The following is a description of a gene set: Abnormal lacrimal punctum morphology studied in species Homo sapiens An abnormality of the lacrimal punctum, an opening on the eyelid close to the medial canthus that drains tears from the conjunctival sac into the lacrimal duct in the same eyelid. Human Gene Set: HP_ABNORMAL_LACRIMAL_PUNCTUM_MORPHOLOGY, and this is the list of marker genes: FGFR3, FOXL2, FGFR2, TP63, UBR1, GLI2, PPP2R3C, FGF10